Given this list of marker genes MMP13, TRPV4, SLC39A13, CCN6, COL9A1, TBX4, KIF7, ACAN, SLC26A2, IFT122, CHST3, CANT1, RAB33B, TRPS1, GNPTG, COL9A2, COL2A1, SLC10A7, TONSL, KIF22, AIFM1, UFSP2, EIF2AK3, PTH1R, here is a description of the gene set: Human Gene Set: HP_FLATTENED_EPIPHYSIS studied in species Homo sapiens Abnormal flatness (decreased height) of epiphyses. Flattened epiphysis